Given this list of marker genes ZBTB14, ABO, RAD51D, ZNF141, FBXL4, EYA1, IFNA10, SMYD3, COL14A1, TNK1, FSHR, ATXN3, DMD, MYH2, ZNF157, SUPT3H (NCBI Gene Id 8464), SERPINA4, GPR18, ATP4B (ATPase H+/K+ transporting subunit beta), MAGEA8, CLCN4, OR2B6, SPA17, DBT, ISL1, GYPA, POLR1HASP, IPO9, RREB1 (ras responsive element binding protein 1), EDIL3, THPO, ATP10B, ITGBL1, KLHL23, ITIH3 (NCBI Gene Id 3699), SLC4A8, HNF1A, GLRA3, IL4, DOCK3, TBX19, LDB3, APOBEC1, MAGEA9, SLC6A2, CALN1, DRD1, EHHADH, NPFF, ZNF132, PCDHB17P, GCA, PTPRB, ABCB10, HSPA1L, NHEJ1, HTR1E, CEP162, FAM110B (family with sequence similarity 110 member B), PRKCA, CXCL5, FZD5, JRKL, KRT34, MAP3K1, SOAT2, CDR1, RYR3, COL8A1, CAMK4, ATF2, CADM4, IL7, ZSCAN26, MON2, FLRT2, FUT1 (NCBI Gene Id 2523), ERC2-IT1, IFNW1 (interferon omega 1), TLL1, NR3C2, PART1, TTTY1, TPD52L1, GNG4, COL19A1, PCM1, OR10H3, CRHR1, GUCY2C, ADGRL2, PSG1 (NCBI Gene Id 91730), PLPPR4, SLC17A1, PHOX2B, HCRTR2 (hypocretin receptor 2), NTNG2, DNAJC22, JADE3, HSD3B2, H3C6, SLC15A1, LILRA1, PPM1E (protein phosphatase, Mg2+/Mn2+ dependent 1E), BRINP3, ABCB1, IFNA1, GUCY2F, RB1CC1, CAMTA1, B4GALT6, ADAMTSL3, CYP2E1, CPB2 (carboxypeptidase B2), SIX6, GPR171, RORB, EXOC4, GCM1 (glial cells missing transcription factor 1), PGM3, CDC73, CDH8, MLLT10, LGI1, KLRC4, KRT2, AOC4P, PDE6A, here is a description of the gene set: Neighborhood of THPO studied in species Homo sapiens Human Gene Set: MORF_THPO Neighborhood of THPO thrombopoietin (myeloproliferative leukemia virus oncogene ligand, megakaryocyte growth and development factor) in the MORF expression compendium